The following is a description of a gene set: from publication Cui A, Huang T, Li S, Ma A, Pérez JL, Sander C, Keskin DB, Wu CJ, Fraenkel E, Hacohen N (PMID 38057668) Genes negatively differentially expressed in cell type: CD8+ T cell upon treatment with cytokine: EGF in mouse lymph nodes in vivo. Cytokines mediate cell-cell communication in the immune system and represent important therapeutic targets. A myriad of studies have highlighted their central role in immune function, yet we lack a global view of the cellular responses of each immune cell type to each cytokine. To address this gap, the authors created the Immune Dictionary, a compendium of single-cell transcriptomic profiles of more than 17 immune cell types in response to each of 86 cytokines (>1,400 cytokine-cell type combinations) in mouse lymph nodes in vivo. A cytokine-centric view of the dictionary revealed that most cytokines induce highly cell-type-specific responses. For example, the inflammatory cytokine interleukin-1β induces distinct gene programmes in almost every cell type. A cell-type-centric view of the dictionary identified more than 66 cytokine-driven cellular polarization states across immune cell types, including previously uncharacterized states such as an interleukin-18-induced polyfunctional natural killer cell state. Mouse Gene Set: CUI_T_CELL_CD8_EGF_RESPONSE_DN species: Mus musculus, and this is the list of marker genes: Zfp36l2, Bcl2, Fos, Tsc22d3, Uba52, Klf6